The following is a description of a gene set: species: Mus musculus Reactome Pathway: GRB2:SOS provides linkage to MAPK signaling for Integrins part of: Integrin signaling This event has been computationally inferred from an event that has been demonstrated in another species.<p>The inference is based on the homology mapping from PANTHER. Briefly, reactions for which all involved PhysicalEntities (in input, output and catalyst) have a mapped orthologue/paralogue (for complexes at least 75% of components must have a mapping) are inferred to the other species. electronically inferred by orthology from the curated human pathway, and this is the list of marker genes: Itga2b, Fgg, Grb2, Ptk2, Apbb1ip, Tln1